The following is a description of a gene set: studied in species Homo sapiens Human Gene Set: GOBP_OLFACTORY_BULB_INTERNEURON_DEVELOPMENT The process whose specific outcome is the progression of an interneuron residing in the olfactory bulb, from its initial commitment, to the fully functional differentiated cell., and this is the list of marker genes: RAC1, ARX, WNT5A, ROBO1, SLIT2, ATF5, ROBO2, SLIT3, SLIT1